Given this list of marker genes CCNB1, CDCA8, NCAPG2, NUF2, ANAPC15, ZWILCH, SPC24, DUSP1, NCAPH, ANAPC7, CENATAC, TRIP13, ANAPC11, ANAPC5, PRAP1, BUB3, KLHL22, BUB1, SPDL1, NCAPD3, KNTC1, BIRC5, MAD1L1 (NCBI Gene Id 8379), DLGAP5, PSMG2, MAD2L1, ATM, SPC25, DIS3L2, TPR (NCBI Gene Id 7175), INCENP, CUL3, CDK5RAP2, CENPF, UBE2C, SMARCAD1, SKA3, SMC2 (structural maintenance of chromosomes 2), MOS, AURKB, NCAPH2, PLK1, NUMA1, CDC16, HASPIN, KNL1, CDC20, NCAPD2, SKA1, TOP3A, ZNF207, M1AP, NCAPG, BUB1B, PRP4K, PLSCR1, TTK, SMC4, MAD2L1BP, RAD21, MAD2L2, GEN1, LCMT1, ZWINT, DYNC1LI1, MAPK15, RB1, IK, TEX14, CSNK2A1, ZW10, USP44, CDC23, NSMCE2, PPP2R1A, NDC80, FBXO5, RECQL5, ESPL1, CSNK2A2, CHFR, XRCC3, APC, here is a description of the gene set: species: Homo sapiens Human Gene Set: GOBP_CHROMOSOME_SEPARATION The cell cycle process in which paired chromosomes are detached from each other. Chromosome separation begins with the release of cohesin complexes from chromosomes; in budding yeast, this includes the cleavage of cohesin complexes along the chromosome arms, followed by the separation of the centromeric regions. Chromosome separation also includes formation of chromatid axes mediated by condensins, and ends with the disentangling of inter-sister catenation catalyzed by topoisomerase II (topo II).